The following is a description of a gene set: from publication Ochiai K, Maienschein-Cline M, Simonetti G, Chen J, Rosenthal R, Brink R, Chong AS, Klein U, Dinner AR, Singh H, Sciammas R (PMID 23684984) Temporal analysis of B cell activation in vitro using CD40L and IL-2/4/5 cytokines in wild type Irf4+/+ B cells or in mutant Irf4-/- B cells harboring a tet-inducible allele of Irf4. IRF4 expression was restored, or not, in the Irf4-/- background by culturing in the presence of low or high concentrations of doxycycline. The results provide insight in the role of IRF4 expression levels in coordinating different programs of B cell differentiation. Human Gene Set: GSE46606_UNSTIM_VS_CD40L_IL2_IL5_DAY1_STIMULATED_BCELL_DN Genes down-regulated in at day 0 B cell wildtype versus CD40L and IL-2 IL-4 IL-5 stimulated at day 1 B cell wildtype. species: Homo sapiens, and this is the list of marker genes: PWP2, CHD7, NAA20 (N-alpha-acetyltransferase 20, NatB catalytic subunit), UTP3, TDG, CALU, MAD2L2, DRG1, SFXN4, MRPS6 (NCBI Gene Id 64968), TNFSF14, ZBTB32, SHLD2, C1orf198, GTF2A2, ZMPSTE24, CCND3, IFRD2, WT1, TIMM23, SLC5A3, GAL, KIF23-AS1, MSH6, TRIB1, RABIF, SS18L2 (SS18 like 2), RBM18, RRP7A, PALB2, MCRIP2, PHLDA2, PSMC4, MED22, PFAS (NCBI Gene Id 5198), HEY1 (NCBI Gene Id 23462), HSPD1, PRADC1, MRPS34, PAQR7, TLCD1, XPO5, ATG101, DNAJA3, MAN1C1, EED, LDHA, UCK2, LYSMD2, BYSL, EMC8 (NCBI Gene Id 751), EIF3J, OLIG2, AHCTF1, PAM16, USB1 (U6 snRNA biogenesis phosphodiesterase 1), TWNK, FAM50A, HDDC2, NOP56, ZMYND19, TNFRSF1B, NCBP1, MED8, PSMG1, CLIC6, EGR3, PTGER3, SLC35F2, HNRNPDL, ZC3HAV1L, QTRT2, MIR3142HG, SLC25A17, FLT3LG, ADCY9, EFCAB3, RILPL1, BHLHE22, SETD3, EIF1, ATP6V0A2, SYBU, SPEN, CISD3, EIF3B, BCS1L, ENOPH1, KIR2DS2, TRNT1, SERPINB9, LINC02210, WARS1, TAL1 (NCBI Gene Id 6886), KDELR2, PALD1, SOCS1, HNRNPF, LSG1, ZNF232, RPS19BP1, PTPN21, RERE, UMPS, NTAQ1, BUD31, YWHAG, EIF2S2, KLHL21, TRBC1, SH2B3, TBRG4, DUSP14, YTHDF1, RPP40, MAP3K6, PRELID1, BATF3, CDC6, CDC123, GPR55, RUNX1, NSMF, DDX10, DDX47, SNHG17, HSD17B10, UHRF1, SLC37A1, RPP38, MPHOSPH6 (M-phase phosphoprotein 6), TP53RK, SRPRB, IL1A, MCM4, SPIB, NT5DC3, LARP4, ETV5 (NCBI Gene Id 2119), POLR1G, ALAS1, TTL, GALE, SNRNP25, PNPT1, MAFG (NCBI Gene Id 84797), COPRS, MCM10, RNF125, FNDC3B, DGKE, FAM98A, WDR4 (WD repeat domain 4), CD40LG, USP36, PDSS1, NDUFAF6, SLFN11, REXO4, ITPRIPL1, CCND1, MFNG, TACC1, BATF, ISG20L2 (NCBI Gene Id 81875), EN2, ST6GAL1, KLF2, GRPEL1, PKP4, JPT2, TNFRSF12A, RELL1, ZNF584, RSL1D1, SRSF7, ESYT1, COLGALT1, RRM2, IQCG, IPO7, BAG5, HILPDA, GINS3, NDUFAF2, BAG1, EEF1E1, DRAXIN, UBIAD1, WDR77, ADORA2B, LSM12, SNX25, PES1, EPOP, CA4, SCG2, ZNF593, ADCY3, GEMIN7